Given this list of marker genes RBM10, CABP1, CDK5, DDX39A, NUP153, YWHAB, SUFU, NF1, APOD, SUMO1, EI24, UFM1, PKIA, SIRT6, FAM76B, RANGAP1, PARK7, BARD1, SP100, CD36, TXN, TPR, MDFIC, NFKBIA, RAB23, ANGPT1, HDAC3, FERMT1, CHP1, PKIG, here is a description of the gene set: Human Gene Set: GOBP_NEGATIVE_REGULATION_OF_NUCLEOCYTOPLASMIC_TRANSPORT species: Homo sapiens Any process that stops, prevents, or reduces the frequency, rate or extent of the directed movement of substances between the cytoplasm and the nucleus.